Given this list of marker genes Tnf, Terf2, Vdr, Htr2b, Tert, Ifng, Gdnf, Gch1, Por, Scarb1, Akt1, Cyp27b1, Atp7a, Esr1, Cdh3, Fgf23, S100a1, Il1b, Dhfr, Fcer2a, Nus1, here is a description of the gene set: Mouse Gene Set: GOBP_POSITIVE_REGULATION_OF_MONOOXYGENASE_ACTIVITY Any process that activates or increases the activity of a monooxygenase. studied in species Mus musculus